The following is a description of a gene set: species: Homo sapiens Abnormality of tibial epiphyses Human Gene Set: HP_ABNORMALITY_OF_TIBIAL_EPIPHYSES, and this is the list of marker genes: RTL1, COL11A1, DLK1, MEG3, COL2A1